The following is a description of a gene set: Absence of one or more interphalangeal creases (i.e., of the transverse lines in the skin between the phalanges of the fingers). Absent phalangeal crease species: Homo sapiens Human Gene Set: HP_ABSENT_PHALANGEAL_CREASE, and this is the list of marker genes: TBX15, NOG, TNNI2, ROR2, LMX1B, TPM2, RBBP8 (NCBI Gene Id 5932), TLK2, MASP1, MET, ADAMTS15, PIEZO2, COL1A2, IHH, HOXD13, MYH3 (myosin heavy chain 3)